The following is a description of a gene set: studied in species Homo sapiens The synthesis of small nuclear RNA (snRNA) from a DNA template. Human Gene Set: GOBP_SNRNA_TRANSCRIPTION, and this is the list of marker genes: SNAPC4, MYOD1, ELL3, CC2D1A, SNAPC1, ELL, ICE1, SNAPC2, SNAPC5, POLR3B (NCBI Gene Id 55703), LARP7, RPAP2, USPL1, SNAPC3, MEPCE, CDK7, ZC3H8, ZNF143, ICE2, ELL2